The following is a description of a gene set: The pattern specification process that results in the subdivision of an axis or axes of the neural plate in space to define an area or volume in which specific patterns of cell differentiation will take place or in which cells interpret a specific environment. species: Mus musculus Mouse Gene Set: GOBP_NEURAL_PLATE_REGIONALIZATION, and this is the list of marker genes: Fuz, Celsr2, Tbx18, Ofd1, Nog, Bmpr1a, Ssbp3